The following is a description of a gene set: studied in species Mus musculus Mouse Gene Set: GOMF_ACYL_COA_BINDING Binding to an acyl-CoA, a thioester that results from the formal condensation of the thiol group of coenzyme A with the carboxy group of any carboxylic acid., and this is the list of marker genes: Acads, Acbd7, Acadl, Scp2, Soat2, Pank3, Acbd3, Naa80, Pitpna, Gcdh, Hmgcl, Acadvl, Acot7, Pnpla3, Pank1, Hnf4a, Dbil5, Eci2, Soat1, Acbd6, Dbi, Acadm, Acbd5, Eci3, Hadha